Given this list of marker genes XPO7, TIAL1, NELFB, MMS19 (MMS19 homolog, cytosolic iron-sulfur assembly component), GTF2F1, M6PR, TAFAZZIN, EIF4EBP2, USP14, TCOF1 (NCBI Gene Id 6949), PLPBP, ARIH2, VARS1, CAPRIN1, ARID3A, DNAJC8, AFG3L2, TM9SF2, TCEA1, BMI1, PRPF8, UBE2D2, HMGN4, COPS2, AP3S1, ZNF131, SMNDC1, PRKCSH, B4GALT3, ATP11B, MFSD10, PTDSS1, HNRNPL, CDKN2C, HNRNPD, TXLNA, PSD4, DIAPH1, CAPZA1, SLC43A1, GTF2A2, CS, GRK6 (G protein-coupled receptor kinase 6), PDXDC2P-NPIPB14P, PRKDC, DYRK2, SREBF2, CNOT1, ESD, SERP1, CAD, SH3BGRL, PABPN1 (poly(A) binding protein nuclear 1), ACAP2, GNB1, DKC1, POM121, MGAT1, POLR2A, CCT4, ZPR1, CNP, PITPNM1, SEC63, RPA2, CSK, PAPSS1, ATXN2L, SRRM1, PCBP3, PPIE, NUDT3, INPP5D, RFC1, RPN1, DCAF7, TNPO3, CELA2A, DGKZ, KXD1, VDAC3, here is a description of the gene set: Neighborhood of BMI1 species: Homo sapiens Neighborhood of BMI1 B lymphoma Mo-MLV insertion region (mouse) in the MORF expression compendium Human Gene Set: MORF_BMI1